The following is a description of a gene set: A process that is carried out at the cellular level which results in the assembly, arrangement of constituent parts, or disassembly of the nuclear envelope. Mouse Gene Set: GOBP_NUCLEAR_ENVELOPE_ORGANIZATION species: Mus musculus, and this is the list of marker genes: Chmp1b (NCBI Gene Id 67064), Banf1, Tor1aip1, Lmnb1, Lmnb2, Nup155, Chmp6, Dctn1, Pafah1b1 (platelet-activating factor acetylhydrolase, isoform 1b, subunit 1), Tmem170, Chmp4b, Cdan1, Akap8l, Dmpk, Cdk1, Ctdnep1, Ubxn2a, Chmp2a, Vps4b, Sun1, Chmp1b2, Reep3 (NCBI Gene Id 28193), Lemd3, Chmp3, Lmna, Lemd2, Spast, Nsfl1c, Brox (BRO1 domain and CAAX motif containing), Parp11, Chmp2b, Tmem43, Chmp7, Ankle2, Reep4, Nemp1 (nuclear envelope integral membrane protein 1), Vps4a, Tor1a, Tmem201, Plk1, Ndel1, Atr, Tardbp, Emd, Gper1, Chmp4c, Des, Ubxn2b (NCBI Gene Id 76194), Zmpste24 (NCBI Gene Id 230709), Chmp5 (charged multivesicular body protein 5), Sun2, Chmp1a (NCBI Gene Id 72909), Nup93, Tor1b